The following is a description of a gene set: Reactome Pathway: PTK6 Regulates Cell Cycle This event has been computationally inferred from an event that has been demonstrated in another species.<p>The inference is based on the homology mapping from PANTHER. Briefly, reactions for which all involved PhysicalEntities (in input, output and catalyst) have a mapped orthologue/paralogue (for complexes at least 75% of components must have a mapping) are inferred to the other species. studied in species Mus musculus electronically inferred by orthology from the curated human pathway part of: Signaling by PTK6, and this is the list of marker genes: Cdk4, Ccnd1, Ccne1, Cdkn1b